The following is a description of a gene set: Human Gene Set: WP_TCELL_ACTIVATION_SARSCOV2 studied in species Homo sapiens T-cell activation SARS-CoV-2, and this is the list of marker genes: LTA, ZAP70, FYN, IL12RB1, IRF2BPL, HLA-DRA, MAPK1, IL17A, IKBKB, PPP3CC, CD28, SOS1, NFKB1, CD3G, DEPTOR, PRKCQ, MTOR, MAPK3, CD86, LCP2, BCL2L1, ITPR1, CDKN2A, MYD88, STAT4, IL2, ICOS, TNF, GRAP2, IL18R1, IFNAR1, FOS, CD4, IL12A, CD3E, FOXO3, JAK2, TYK2, MALT1, RICTOR, IFNG, RASGRP1, IL4, CCL19, CD3D, PTEN, MAP2K1, GSK3B, LCK, GRB2, IL12B (interleukin 12B), BAX, IKBKG, CCND1, TSC1, MAP2K2, HLA-DRB1, CD80, NFATC1, IL23A, RHEB, CDKN1A, CTLA4, RPTOR, HRAS, TSC2, AKT1, IL12RB2, IFNB1, PTPRC, PIK3R1, CHUK, RELA, PDPK1, CD247, IFNAR2, PIK3CD, MLST8, NFKBIA, PLCG1, CARD11 (caspase recruitment domain family member 11), TP53, JUN, LAT, IL23R, RAF1, CCL28, BCL10